Given this list of marker genes IL18R1, IL1R1, IL18, IL1B, SLAMF1, ARID5A, XCL1, TBX21 (T-box transcription factor 21), here is a description of the gene set: Human Gene Set: GOBP_T_HELPER_1_CELL_CYTOKINE_PRODUCTION Any process that contributes to cytokine production by a T-helper 1 cell. studied in species Homo sapiens